The following is a description of a gene set: Mouse Gene Set: HALLMARK_COMPLEMENT from publication Howe DG, Blake JA, Bradford YM, Bult CJ, Calvi BR, Engel SR, Kadin JA, Kaufman TC, Kishore R, Laulederkind SJF, Lewis SE, Moxon SAT, Richardson JE, Smith C (PMID 30224793) studied in species Mus musculus Mouse genes annotated to HALLMARK_COMPLEMENT based on orthology mappings provided by the Alliance Genome Consortium, and this is the list of marker genes: Kcnip2, F3, Lrp1, Ctsc, Car2, Plscr1 (NCBI Gene Id 54533), Ctsl, Prcp, Calm1, Dusp6, Ccl5, C9, Jak2, Cd40lg, Csrp1, Irf7, Tfpi2, Serpinb2, Pik3cg, Klkb1, Itgam, Dusp5, F10, Ctsh (cathepsin H), Sh2b3, Gzmk, Plat, Dock10, Atox1, Rbsn, Cblb, Serping1, Kif2a, Gpd2, Timp1, Serpinc1 (serine (or cysteine) peptidase inhibitor, clade C (antithrombin), member 1), Hnf4a, Ppp2cb, Zeb1, Adra2b, Cr2, Kcnip3, Dpp4, Mmp13, Lcp2, Ctsd, Olr1, Ehd1, Fcer1g, Col4a2, Lap3, Cfh, Adam9, Mmp15, Irf2, F7, Ang, Pik3r5, Casp1 (caspase 1), Rhog, Msrb1, Ppp4c, Dgkg, Clu, Zfpm2, Casp9, Ltf, Lck, Klk1 (NCBI Gene Id 68329), Fcnb, Cda, Pim1, F5, Pdgfb, F8, Prkcd, Fdx1, Rasgrp1, Tnfaip3, Lyn (NCBI Gene Id 99963), Tmprss6, Lgals3, Gp9, Pcsk9, Me1, Mmp12, Usp16, Ctso, C1qa, Usp15, Cd46, Cdk5r1, Timp2, Actn2, Gnb2, Plaur, Plek, Gngt2, Usp14, Calm3, Cebpb, Mmp14, Pclo, L3mbtl4, C2, Plg, Stx4a, Prep, Brpf3 (NCBI Gene Id 268936), Scg3, Phex, Apoc1, Fyn, Serpine1, Cd36, Irf1, Pdp1, Lgmn, Prdm4, Gng2, Il6, Casp4, Casp7, Itih1, Hpcal4, Psmb9 (NCBI Gene Id 16912), Ctsb, Gmfb, Pla2g7, Dock9, Fn1, Cpm, Psen1, Dock4, Pla2g4a, C1qc, Gnb4, Gzmb, Maff, Rabif, Mt3, S100a13, F2, Vcpip1, Raf1, Sirt6, Pik3ca (NCBI Gene Id 70742), Gca, Mmp8, C1s1, Hspa5, Cdh13, Cpq, Pfn1, S100a9, Apoa4, Notch4, Gzma, Cfb, Ctss, C3, Rce1, Gnai3, Was, Usp8, Cp, Spock2, Gnai2, Casp3, Grb2 (growth factor receptor bound protein 2), Anxa5, Gata3, Src, Hspa1a, Dyrk2, Prss36, Akap10 (NCBI Gene Id 69013), Xpnpep1, Gp1ba, Dgkh, Lta4h, Rnf4, Lipa, Lamp2, Kynu